Given this list of marker genes TMEM74, MYC, PYCR3, ZNF7, EPPK1, PTP4A3, MROH5, TNFRSF11B, DEPTOR, JRK, KLHL38, RNF139, LRRC24, LY6K, MRPL13, SLA, ANXA13, MAF1, TRMT12, SLC30A8, KCNQ3, KCNV1, TONSL, ADGRB1, CYC1, GPR20, MTBP, COL14A1, MTSS1, BOP1, RAD21, LRATD2, TRHR, LY6E, FBXL6, VPS28, CYP11B1, TRAPPC9, NSMCE2, NUDCD1, TBC1D31, PHF20L1, ARC, TIGD5, SHARPIN, THEM6, LY6D, RECQL4, DSCC1, ZHX1 (zinc fingers and homeoboxes 1), SNTB1 (NCBI Gene Id 6641), HSF1, ZFP41, SYBU, AARD, PPP1R16A, TOP1MT, PSCA, GSDMD (gasdermin D), ENY2, CYP11B2, ST3GAL1, LYNX1, MROH1, GPT, SLC39A4, ZHX2, KCNK9, TRPS1, ZNF34, RHPN1, LY6S-AS1, ENPP2, FAM83H, CPSF1, PKHD1L1, ZFTRAF1, MED30, FAM83A (NCBI Gene Id 84985), SLC52A2, LYPD2, LY6H, ZNF707, TMEM71, GFUS, FOXH1, GML, GLI4, GPAA1, ZNF623, ZNF517, AGO2, ZNF572, MAFA, FER1L6, DERL1, TATDN1, SPATC1, PLEC, C8orf82, NDUFB9, SLURP1, EXT1, ATAD2, NDRG1, C8orf33, ARHGAP39, TAF2, HGH1, CSMD3, ZNF250 (NCBI Gene Id 58500), DENND3, TMEM65, DNAAF11, HAS2, PUF60, ZNF16, CHRAC1, ADCK5, PTK2 (protein tyrosine kinase 2), TRIB1 (tribbles pseudokinase 1), EEF1D, NAPRT (nicotinate phosphoribosyltransferase), LRRC14, C8orf76, FBXO32, SLC45A4, COMMD5, TG, SQLE, GRINA, SCX, TSNARE1, COLEC10, MAL2, SCRIB, PARP10, ZNF251, KIFC2, ZNF696, OPLAH, EXOSC4, CCN4, MFSD3, RPL8, EBAG9, NRBP2, CCN3, SAMD12, ZC3H3, GPIHBP1, MAPK15, EIF3H, UTP23 (UTP23 small subunit processome component), WASHC5, NTAQ1, FAM91A1, here is a description of the gene set: Genes within amplicon 8q23-q24 identified in a copy number alterations study of 191 breast tumor samples. from publication Nikolsky Y, Sviridov E, Yao J, Dosymbekov D, Ustyansky V, Kaznacheev V, Dezso Z, Mulvey L, Macconaill LE, Winckler W, Serebryiskaya T, Nikolskaya T, Polyak K (PMID 19010930) A single cancer cell contains large numbers of genetic alterations that in combination create the malignant phenotype. However, whether amplified and mutated genes form functional and physical interaction networks that could explain the selection for cells with combined alterations is unknown. To investigate this issue, we characterized copy number alterations in 191 breast tumors using dense single nucleotide polymorphism arrays and identified genes with copy number gain organized into 30 amplicons. Amplicons were distributed unequally throughout the genome. Each amplicon had distinct enrichment pattern in pathways, networks, and molecular functions, but genes within individual amplicons did not form coherent functional units. Genes in amplicons included all major tumorigenic pathways and were highly enriched in breast cancer-causative genes. In contrast, genes with somatic mutations in breast cancer were distributed randomly over the genome, did not represent a functionally cohesive gene set, and were relatively less enriched in breast cancer marker genes. Mutated and gained genes did not show statistically significant overlap but were highly synergistic in populating key tumorigenic pathways including transforming growth factor beta, WNT, fibroblast growth factor, and PIP3 signaling. In general, mutated genes were more frequently upstream of gained genes in transcription regulation signaling than vice versa, suggesting that mutated genes are mainly regulators, whereas gained genes are mostly regulated. ESR1 was the major transcription factor regulating amplified but not mutated genes. Our results support the hypothesis that multiple genetic events, including copy number gains and somatic mutations, are necessary for establishing the malignant cell phenotype. species: Homo sapiens Human Gene Set: NIKOLSKY_BREAST_CANCER_8Q23_Q24_AMPLICON